The following is a description of a gene set: part of: Dopamine clearance from the synaptic cleft Reactome Pathway: Enzymatic degradation of dopamine by COMT Dopamine once taken up by the dopamine transporter from the extracellular space into the cytosol is metabolized in a two step reaction to homovanillic acid.The first reaction is catalyzed by catecholamine o-methyl transferase and the subsequent reaction is catalyzed by monoamine oxidase A. species: Homo sapiens, and this is the list of marker genes: TOMT (NCBI Gene Id 120356740), MAOA, COMT